Given this list of marker genes Bpifc, Ptx3, Npy5r, Map3k8, Plaur, Usp25, Lhfpl4, Or51e2, Ppp1r3b, Maob, Zdhhc21, Phaf1 (phagosome assembly factor 1), Arhgap12, Adam9, Cep350, Nup93, Btf3l4, Rabgap1 (NCBI Gene Id 227800), Fam184a, Klhl2, Mgam, Fezf1, Zfp281, Pcdha6, Nemp1, Bcl7a, Epha4, Myo1b, Mcf2l, Krit1, 1700028K03Rik, Slc8a1, Pcdha10, Ptchd4, Pcdha12, Pcdha4, Grb2, Slc17a6, Ahnak, Mllt6, Csnk1g3, Scml4, Rnf19b, Ebf2, Atp11c, Piwil1, Zfp239, Pcdha5, Slf2, Irf2bp2, Hey1, Pid1, Slc16a10, Lonrf1, Zfyve1, Rp2, Dusp22, Kif3c, Kbtbd2 (NCBI Gene Id 210973), Pcdhac1, Hpcal4, Zfhx4, Mark1 (MAP/microtubule affinity regulating kinase 1), Pcdha11, Tceal8, Gpr146, Bcl9, Rai1, Eno2, A330070K13Rik, Chmp3, Ilrun, Pcdh10, Akain1, Caprin1 (NCBI Gene Id 99144), Fam53c, Srsf4, Clec2h, Ddx47, Pcdha2, Ccer1, Shb, Lnpk, Emc1, Dusp10, Dclk1, Akap8, Ptprj, Zbtb18, Snrk, Atp2a3 (NCBI Gene Id 53313), Coa7, Pcdha3 (NCBI Gene Id 192163), Mapre1, Bmerb1 (NCBI Gene Id 67254), Tbc1d24, Ubn1, Raph1, Brd8, Dync2i2, Larp4b, Rmnd5a, Rtl5, Ppp1r14c, Zc3h7b, D430041D05Rik, Zfp26, Luc7l2, Blcap, Foxo1, Ddx19b, Atxn1, Ewsr1, 4930596D02Rik, Ssbp2, Dlgap4, Trak1, Commd6, Slc12a2 (NCBI Gene Id 20496), Pcdhac2, Pcdha9, Pcdha1, Tent4b, Tnrc6b, Prkacb, Pes1, Arhgap11a, Lrp2bp, Pfkfb2 (6-phosphofructo-2-kinase/fructose-2,6-biphosphatase 2), Kcnj5, Fhip2a, Zfp655, Gigyf1, Pcdha7, here is a description of the gene set: from publication Chen Y, Wang X (PMID 31504780) Mouse Gene Set: MIR_362_3P species: Mus musculus Genes predicted to be targets of miRBase v22 microRNA mmu_miR_362_3p in miRDB v6.0 with MirTarget v4 prediction scores > 80 (high confidence targets).